Given this list of marker genes Actg1, Men1, Tubb4a, Tuba1a, Calm1, Clip1, Rac1, Tubb2b, Tuba3a, Tubal3, Cdc42, Tuba1b, Iqgap2 (NCBI Gene Id 71188), Tuba3b (tubulin, alpha 3B), Calm2, Iqgap1 (NCBI Gene Id 52178), Tubb4b, Actb, Tuba4a, Ctnna1, Ctnnb1, Tubb1, Calm3, Tuba1c, Tubb2a, Tubb3 (tubulin, beta 3 class III), Tubb6, Iqgap3, Tuba8, here is a description of the gene set: species: Mus musculus RHO GTPases activate IQGAPs Mouse Gene Set: REACTOME_RHO_GTPASES_ACTIVATE_IQGAPS